Given this list of marker genes Egfr, Prss45, Cops5, Cma1, Ivns1abp, Prkn, Thop1, Capn12, Agbl4, Smurf1, Usp46, Hdac6, Kctd10, Psmb10, Fbxl7, Canx, Smurf2, Aopep, Mmp1a, Atxn3, Amz2, Ccdc47, Man1a, Yod1, Gzmf (granzyme F), Adamts17, Psen2, Klk1b4, Ankrd9, Dpep3, Nlrc4, Timp1, Usp42 (NCBI Gene Id 76800), Mbp, Psmd10, Ins1, Prss54, Lonp1, Pramel17, Tmprss11b, Ube3a, Cav1, Rnf150, Psme4, Wdr77, Rnf186, Pramel22, Serpinb10, Prss8, Cts6, Sgta, Kel, Armc8, Apc2, Arrb2, Arrdc4, Ero1b, Nedd4l, Try4, Shh, Clpx, Ubxn11, E330034G19Rik, Prss28 (serine protease 28), Gm15441, Ufd1, Tnp1, Adam6b, Chmp7, Ufl1, Cstdc4, Calr3, Klhl23, Usp37, Get4, Usp16, Tlk2, Psenen, Gclc, Rnf19a, Pidd1, Chmp2a, Cpa2, Rnf26rt, Klk7, Apoe, Ist1, F11, Tmprss7, Fbxo10, Brcc3, Htra2, Klhl4, Dnajb12, Snx9, Kbtbd6, Spink5, Ctsq (cathepsin Q), Adam15, Psme3ip1, Cfd, Ube4a, Ctsk, Senp1, Ptpn23, Lnpep, Usp1, Prkcq, Rnf144a, Trim32, Pramel25, Pramel53, Nupr1, Midn, Klk4, Rbp3, Saysd1, Trim38, Cpd, Kbtbd3, Faf2, Umod, Sh3rf1, Scrn1, Ube2l6, Trim9, Prpf19, Klhl20, Chmp2b, Fbxo48, Prickle1, Prss22, Immp1l, Senp5, Proc, Pramel31, Pcsk4, Osbpl7, Timm23, Ube2j2, Ptk2, Klhl6, Man1b1, Stambpl1, Adamts2, Sco1, Trim71, Pcsk7, Ovch2, Pramel32, Rbx1-ps (ring-box 1, pseudogene), Ecm1, Jmjd7 (jumonji domain containing 7), Psmd8, Ankrd11, Afg2b, Trim3, Gzmc, Cdc34, Clec16a, Rnf8, Tmprss9, Ide, Oga, Znrf4, Nemf, Cul1, Vps25, Mta1, Ddb1, Klk1b5, Dpp9, Actmap (NCBI Gene Id 434154), Pgpep1, Serpinb6c, Casp2, Axin1, Prss23, Serpinb6b, Bap1 (NCBI Gene Id 69465), Fbxo39, Bace2 (NCBI Gene Id 68803), Pja2, Dcaf13, Kctd6, Pitrm1, Anapc10, Tpsg1 (NCBI Gene Id 26945), Fbxo22, Foxf2, Maea, Spg7, Folh1, Dpp3, Dhh, Arxes1, Ttc3, Timp4 (NCBI Gene Id 21860), Cdk5rap3, Adam29, H2bc1, Sfrp2, Psme1, Corin, Pramel14 (NCBI Gene Id 670969), Cpne1, Adam24, Ace3, Ctsc, Ihh, Pramel6, Rnf10, Capn10, Cpa4, Adra2a, Rbmxl1, Mbtps1, Cul4a, Tdpoz3, Mindy1, Tmprss3, Efna3, Uba6, Ins2, Cdc27, Usp28, Cops3, Psma3, Pramel7 (NCBI Gene Id 97653), Map1a, Asprv1, Skp1, Cpxm1, Adam18, Ube2j1, Pga5, Usp38, Proz, Ipp, Tgfb1i1 (transforming growth factor beta 1 induced transcript 1), Dvl1, Ubr5, Anapc16, Cul3, Pramel38, Siah1a, Pramel33, Usp32, Pcsk2, Gapdhrt, Traf4, Serpinb9, Endou, Tmem259, Xbp1, Birc2, Adam1a, Adam3, Hipk2, Klhl17, Uspl1, Hspa5, Aph1b, Derl2, Cln5, Gm13040, Tpp1, Plaa, Mpnd, Cyfip2, Anxa2, Pramel47, Bmp1, Cnot4, Dtx3l, Mep1b, Anapc4, Klhl30, Ube2s, Snhg15, Prss36, Serpinb1b, Aph1a, Ubap1, Fau, Ctsl, Skp2, Ecscr, Tll2, Mindy3, Rnf170, Usp3, Psma2, Serpinf2, Tmem98, Rnf128, Dnajc3, Ubb, Prss39, Rnf126, Tdpoz5, Filip1l, Pramel13, Lats1, Hamp, Dcaf1, Otulin, Wdr26, Casp6, Cst7, Tspan15, Prmt6, Klhl7, Nhlrc1, Tinagl1, Cd46, Adam21, Matcap1, Bbs7, Parl, Usp18, Casp4, Cldn3, Brcc3dc, Serpinb9c, Psmb1, Otud7b, Hspbp1, Bfar, Topors, Agap3, Ctsh, Cstl1 (cystatin-like 1), Axin2, Pramel35, Nr1h2, Adam12, Mmp3, Psmb8, Ptpn1, Elane, Asb2, Zfand2a, Ctrc, Meltf, Ubxn2b, Det1, Anapc15-ps, Spcs1, Cpb2, Trim39, Bmal1 (NCBI Gene Id 11865), Ube2v2, Cpq, Sel1l, Tmem67, Fbxl2 (F-box and leucine-rich repeat protein 2), Klhl18, Rnf146, Tmub1, Pcbp2, Tysnd1, Spock1, Bag5, 1810009J06Rik, Fbxl15, Trp53inp2, Lap3 (leucine aminopeptidase 3), Pcsk6, Csnk1d, Klhdc3, Lactb, Herc2, Commd1 (COMM domain containing 1), Kctd17 (NCBI Gene Id 97993), Cpz, Kbtbd12, Yipf5, Nup98, Clca1, Rnf43, Prss40 (serine protease 40), Usp43 (ubiquitin specific peptidase 43), Map3k1, Ctsf, Styx, Mmel1, Spink2, Ptch1, Rnf216, Mkrn2, Pramel29, Atp13a2, Metap1 (NCBI Gene Id 99872), Oma1, Klhl12, Josd2, Acp4, Fbxl18 (NCBI Gene Id 231863), F12, Fbxo3, Adam20, Klk1b27, Adgrv1, Capn3, Gm2663, Rnf111 (ring finger 111), Cela3a, Ubxn10, Psmd13, Rgn, Plg, Sel1l2, Pramel12, Pramel24, Oog3, Rybp, Rack1, Agbl1, Snx33, Htra1, Cop1, Mib1, Glmn, Ubl7, Cndp1, Ogt, Asb9, Mindy4, Tmem208, Ift172, P4hb, Pik3c3, Cpa1, Immp2l, Ube2d2a, Lrrc75a, Fbxo11, Pisd, Afg1l, Ctsa, Ubqln2 (ubiquilin 2), Psma6, Pramel43, Tmem168, Klhl15, Rhbdl3, Prss44, Rhbdl2, Hint1, Ltn1, Adam19, Akt1, Ermp1, Rpl5, Clgn, Desi2, Epm2a, Enpep, Vps37b, Chfr, Klk1b1 (NCBI Gene Id 16623), Rnf180, Sirt1, Usp45, Rnf121, Usp7, Ccdc22 (NCBI Gene Id 54638), Vhl (NCBI Gene Id 22346), Fbxo8, Cdc34b, Fbxl19, Fhit, Tdpoz1, Psma8, Prss3, Pkd1, Serpinb9f, Rnf103, Tspan5, Pramel30, Traf3, Zyg11b, Gzmg, Pramel19, Csnk1e, Edem2, Lrig2, Pten, Afg3l2, Gzmb, Spink1, Pramel28, Rcn3, Amz1, Lrrk2, Usp36, Gabarap, Cdc26, Ece1, Cela3b, Brsk2, Ctsd, Ube2z, Psmb3, Znrf2, Vps4a, Ube2g2, Cpn1, Usp17le, Cyld, Anapc1, Espl1, Pramel15, Prss58, Usp33, Pramel23, Adam10, Pramel18, Trim26, Habp2, Eno1b, Capn8 (calpain 8), Adamts20, Ube3b, Oaz1, Rffl, Rnf123 (NCBI Gene Id 84585), Dcaf11, Gzmn, Fbxl17, Rhbdf1 (NCBI Gene Id 13650), Hspa1a, Rnf115, Ubxn4, Gzmd, Csta2, Rmnd5b, Plk3, Lvrn, Mmp12, Gzme, Eef1ece2, Pcsk1, Timp2, Fadd, Chmp1a, Mindy2, Siah2, Gapdhrt2, Nop53, Nccrp1, Psma7, Pappa2, Spopfm2, Astl, Serpinb9b (serine (or cysteine) peptidase inhibitor, clade B, member 9b), Prss2, Dpp6, Pcyox1l, Apc, Rbx1, Cdc20, Metap2, Csnk1a1, Derl3, Pcyox1, Napsa, Usp4, Slc30a8, Ubac2, Npepl1, Capn15, Rnf185, Cul9, Cast, Hspa8, Psmd3, Spock3, Adamts19, Sppl2a, Comp, Vps28, Chmp4c, Otud6b, Usp34, Ift52, C1rb, Serpinb9h, Sumo1, Tpsab1, Tnf, Zmpste24, Ctnnb1, Myc, Dync2h1, Kbtbd2, Kat5, Usp17lc, App, Alg13, Usp24, Vash2, Ctsj, Perp, Sva, Ecel1, Adamts8 (NCBI Gene Id 30806), Socs2, Gsk3b, Serpinb6d, Dlgap1, Rnf144b, Mmp25 (matrix metallopeptidase 25), Fbxl12, Trib2, Psmb11, Pepd, Prss38, Vash1, Clpp, Egf, Cdh1, Adam26a, Rnf26, Capn11, Herpud1, Fbxw8, Appbp2, Otub1, Adam8, Rnf149, Tpp2, Hace1, Fbxl6 (F-box and leucine-rich repeat protein 6), Trim31 (NCBI Gene Id 224762), Pbk, Herc4, Desi1, Ube2u, Tbl1xr1, Klk14, Serpinb13, Mmp9, Fbxl20, Nedd8, Matcap2, Capn7, Ren1, Adamts5, Chmp1b2, Vps37d, Hp, Adam34l, Syvn1, Dpep2, Klhl5, Disp1, Mbl2, Casp8, Ubqln3, Klhl24, Fbxo9, Stoml2, Edem3, Socs4, Cntn2, Ntan1, Chst8, Tmem129 (transmembrane protein 129), Prss3b, Nrros, Pmpcb, Zfp598, Huwe1, Hspa1b, Socs7, Pdcl3, Rab23, Hecw1, Adamts6, Usp21, Ube2d3, Kdm8, Prss53, Fetub, Tasp1, Senp2, Fuz, Prss37, Oog1, Cfh, Gan, Cela2a, Prelid1, Inpp5b, F9, Gba1, Ecpas, Serpinb8, Acr, Pdcd6ip, Prss57, Arel1, Blmh, Mst1, Cul5, Serpinb1c, Adamts9, Lmln, Prss3l (NCBI Gene Id 100044144), Dpp4, Senp6, Ager, Serpinb9d, Atp6ap2, Il1b, Trim25, Prcp, Phf20l1, Cfhr4, Dpep1, Kbtbd7, Rnf7, Klk1b22, Cpa5, Dtx4, Ctrb1, Rnf25, Pramel48, Gzma, Vcp, Tmub2, Ky, Csta3, Stambp, Tmprss11e, Dnpep, Uchl5, Rnf5, Fbxo44 (NCBI Gene Id 50763), Rnf133, Rfx4, Fbxl22, Psmf1, Vps4b (vacuolar protein sorting 4B), Rnf148, Sec11c, Dab2ip, Cln3, Cfi, Nfe2l2, Nln, Pgc, Rnf13, Otub2, Prss1, Ift80, Ctsr, Stfa2, Fkrp, Hgf, Gabarapl2, Usp48, Ube2l3 (NCBI Gene Id 98018), Scg5, Ltf, Hid1, Rhobtb3 (NCBI Gene Id 74794), Oxa1l, Mipep (mitochondrial intermediate peptidase), Anapc5, Adam11, Ufsp2, Klk1b3, Adam23, Cdc20b, Nrdc, Mtm1, Ecrg4, Uqcrc2, Psmc3, Cpxm2, Atg4a, Socs6, Klhdc10, Rad23a, Cts7, Ddi1, Ctss, Tnfaip1, Wnt1 (NCBI Gene Id 22408), Klhl22, Rnf20, Ift88 (NCBI Gene Id 21821), Prtn3 (proteinase 3), Ctsw, Adam33, Prss34 (serine protease 34), Cstdc3, Rgma, Cym, Znrf3, Vps37a, Atg4b, Mbtps2, Mmp7, Eif3h, Isg15, Oog4, Fbxl4, Prss29, Prss33, Casp12, Klhl10, Casp9, Sppl3 (NCBI Gene Id 83678), Pcolce, Cirop, Rspry1, Fga, Colec11, Ube2c, Trib3, Dtl, Rhbdd1, Pm20d1 (peptidase M20 domain containing 1), Ccar2, L3mbtl3, Tpsb2 (tryptase beta 2), Mysm1, Rhbdf2, Adamts3, Kcmf1, Otud5, Spsb1, Tmprss11d, Pml, Tdpoz9, Pcsk9, Ret, Herc3, Xpnpep2, Trpc4ap, Metap1d, Pramel5, Ube3c, Wwp1, Psme2, Mcpt9, Lonrf2, Chac1, Ubl4a, Angptl8, Rc3h2, Dcaf12, Usp19, Wfdc6a, Eloc, Ddrgk1, Klk1b24, Serpine2, Cndp2, Atg4c, Ubxn8, Prkaca, Tmprss13, Cbfa2t3, Atg7, Epg5, Ubqlnl, Ubqln4, Tmprss5, Klhl42, Phex, Hectd1, Cul7, Snf8, Ifng, Adamts14, Gna12, Ercc8, Ctsz, Arxes2, Chmp4b, Adam5, Pramel45, Arih2, Kctd5, Klk8, Pramel16, Tmprss4, Cul4b, Ggt5, Rnf139, Cplane2, Prkacb, Usp50, Mafb, Rnft1, Rchy1, Alad, Tm4sf20, Prss16, Spopfm3, Cpe, F3, Tgfb1, Tnp2, Ptpn3, Arrdc1, Adamts1, Afg3l1, Klhl41, Trem2, Serpinb1a, Klk1b16, Casp1, Pgpep1l, Ctnnd1, Rnf40, Il1r2, Gpx1, Capn9, Hgfac, Vps37c, Sufu, Cstdc6, Usp22, Anapc15, Klhl8, Trim67, Klhdc2, Pip, Sirt4 (NCBI Gene Id 75387), Rnf130, Sec61b, Tmf1, Asb11, Arrb1, Hjv, Rps7, Clu, Bace1, Dag1, Socs5, Adam25, Mmp11, Herc6, C1ra, Gzmk, Ubqln5, Sharpin, Vps35, Sh3rf3, Pabpn1l, Adamts7, Psmd11, Myrf, Spink6, Wac, Sval1, Pramel21, Fmr1 (fragile X messenger ribonucleoprotein 1), Usp44, Erlin2, Ccnf, Fbxo27, Cpa6, Prss21, Psma4, Dpp10, Dnajb2, Trim13, Pramel51 (NCBI Gene Id 100039315), Tspan17, Cstdc5, Klhl21, Adam4, Spink12, Fap, Cuzd1, Psme3, Cldn4, Rnf7l, Rnf166, Otud3, Ctsg, Crbn, Pm20d2, Prss56, Tbx21, C1s2, Pcsk1n, Uba52, F10, Ube2g1, Ern1, Pramel26, Rbck1, Ube2h, Usp5, Ctse, Zer1, Uchl1, Siah1b, Adamts15, Ubqln1 (NCBI Gene Id 97856), Pramel60, Mme, Vsir, Aph1c, Nrip2, Serpine1 (NCBI Gene Id 231790), Adam28, Ube2k (NCBI Gene Id 53323), Notch4, Klhl38, Serpinb6a, Htra4, Mmp13, Lta4h, Otud4, Fbxo38, Svip, Atg4d, Fbxl14, Ube2b, Mmp15, Lgmn, Uchl4, Ube2d1, Rnf168, Psmb7, Prss43, Nlrp1b, Wfikkn1, Scpep1, F8a, Ece2, Mcpt1, Gapdh, Uba7, Fgfr4, Reck, Klhl1, Fbxo17, Prss41, Ufsp1, Yme1l1, Asph, F2, Pappa, Adam39, Trabd2b, Wfs1, Tmprss12, Lnx1, Cacul1, Scrn3, Anapc11, Kif14, Ace, Sppl2c, Tmprss15, Styx-ps, Cdkn2a, Otud7a, Plk2, Casp14, Pmp22, Ube2srt, Psmd4, Casp7, Ttc36, Cntnap5a, Nudt15, Trib1, Traf7, Spsb4, Adam1b, Ubxn7, Psma1 (proteasome subunit alpha 1), Gipc1, Furin (furin, paired basic amino acid cleaving enzyme), Ankzf1, Ubc, Psmb2, Mmp21, Plgrkt, Hectd3, Klhl2, Pigk, Usp14, Fbxl9, Stat3, Srgn, Atp23, Pmaip1, Ubxn1, Fcnb, St14, Ube2w, Parp1, Mapk8, Apoh, Chmp1b, Itch, Usp27x, Adam34, Pramel44, Mmp17, Rpl23, Rhbdl1, Pik3r1, Klhl40, Ace2, Ctsm, Usp10, Prep, Tmed10, Anapc7, Rnf11, Hsp90ab1, Fbxo45, Capns1, C2cd3, Laptm5, Nrip3, Psmb9, Wwtr1, Tmtc3, Spopl, Kcne2, Usp25, Mcpt8, Adamts18, Bak1, Psmc5, Irgq, Ubxn2a, Fem1c (NCBI Gene Id 67174), Glg1, Usp29, Usp26, Spon1, Tbc1d10a, Serpina5, Ophn1 (NCBI Gene Id 94190), Prss42, Rnpep, Eno1, Taf9, Psmd7, Clec3b (NCBI Gene Id 21922), Usp47, Ascc3, Fem1b, Dab2, Myrfl (NCBI Gene Id 237558), Ctla2a, Adamts10, Ctrl, Selenos, Adamdec1, Src, Capn6, Pithd1, Ark2n, Tor1a, Usp17la, Cldn13, Clca3a1, Usp13, Anapc2, Naaladl1, Dpp7, Fbxl5, Ubr2, Asrgl1, Chmp3, S100a10, Klhl29, Mep1a, Xpnpep1, Lyn, Jkamp, Epha4, Klk1b9, Ppp1r11, Ube2dnl1, Rpgr, Slc30a5, Eif2a, Uba1, Otud6a, Wdr81, Os9, Uchl3, Ubd, Ccbe1, Spcs2, Adamts12, Mmp8, Hdac2, Psmd2, Masp1 (NCBI Gene Id 17174), Gid4, Reln, Rpl11, Klkb1, Pramel40, Ubr1, Gapdh-ps15, Siah3, Akirin2 (akirin 2), Rnf41, Calr4, Tmprss11c, Aebp1, Cd2ap, Senp3, Nub1 (NCBI Gene Id 80634), C1rl, Man1c1, Dda1, Cpb1, Sirt2, Timp3, Rce1, Gsn, Psen1, Rnf114, Prss1l, Dnaaf4, Gid8, Tmx1, Sh3rf2, Aqp11, Ate1, Capn13, Ncstn, Pthlh, Man1a2, Spsb2, Senp8, Trp53, Tmprss6, Cfb, Usp12, Dmac2, Hecw2, Mmp14, Rbbp6 (NCBI Gene Id 97359), Snx12, Gsk3a, Psmd1, Thbs1, Tsg101 (NCBI Gene Id 22088), Ambra1, Csnk2b, Rps6ka2, Psmb6, Ube2r2, Nsfl1c, Il33 (interleukin 33), Anpep, Sirt6, Sumo3, Zswim8, Pramel1, Agtpbp1, Ube3d, Sprtn, Cts8, Agbl3, Zfp418, Tmprss2, Cdc23, Dcst1, Fbxo6, Tdpoz4, Hpn, Vps36, Prss32, Adam6a, Stfa1, Trim28, Bcap31, Edem1, Adam30, Pramel11, Cpm, Bin1, Rnf34, Ptk2b, Pramel27 (PRAME like 27), Fbxo4 (NCBI Gene Id 67521), Adam7, Tdpoz2, Rad23b, Prss50, Hsp90b1 (heat shock protein 90, beta (Grp94), member 1), Brinp1 (bone morphogenic protein/retinoic acid inducible neural specific 1), Capn5, Cts3, Rnf4, Agbl5, Casp3, Cflar, Timm17a, Crb2, Cbl, Serpinb9g, Fbxl13, Ubr4, Tmprss11f, Pacsin3, Cstb, Calr, Derl1 (NCBI Gene Id 67819), Csnk2a2, Nlrp1a, Pabir1, Fbxw4, Psmc1, Eif2ak3, Pramel20, F7, Ctsll3, Anapc13 (anaphase promoting complex subunit 13), Hfe, Nfe2l1, Chmp6 (NCBI Gene Id 69715), Rnpepl1, Nr1h3, Psmd14, Lamp3, Svbp, Usp17ld, Klk1b8, Caml, Stub1, Try10, Fbxw5, Rnf19b, Nkd2, Klhdc1, Usp54, Vtn, Xpnpep3, Masp2 (MBL associated serine protease 2), Asb1, Plaur, Klhl35, Ube2d2b, Sval3, Klhl3, Psmc6 (proteasome (prosome, macropain) 26S subunit, ATPase, 6), Aurkaip1, Tmprss11g, Cblc (Casitas B-lineage lymphoma c), Eif3f, Prss46, Gsap, Csta1, Rnf145 (ring finger protein 145), Fgg, Adamts16, Rnf215, Rps27a, Ppp1r15a, Fbxl3, Mmp16 (matrix metallopeptidase 16), Stam, Znrf1, Grn, Mmp24, Amfr, Ndfip1, Adam22 (a disintegrin and metallopeptidase domain 22), Trim45 (tripartite motif-containing 45), Fam111a, Capn1, Adam9, Klk1b21, Usp30, Ccin, Ube2a, Kctd13, Clca4a, Keap1, Cela1, Klk1b11, Pcnp, Fbxo7, Faf1, Naglu, Rc3h1, Psmb4, Cfl1, Usp9x, Adamts13, Usp9y, Ctso, Bad, Kng2, Tnfrsf1b, Ctsb, Npepps, Marchf7, Dhcr24, Kng1, Zranb1, Hmces, Proca1, Pramel41, Fem1al, Apeh, Antxr1, Dpp8, Mmp10, Sec11a, Kbtbd8, Nedd4, Kctd2, P2rx7, Psmb5, Lonp2, Sh3bgrl, Pramel46, Peli1, Mmp19, Mdm2, Qrich2, Gli3, Trhde, Capn2, Usp2, Klk13, Rbmx, Fem1a, Psma5, Marchf6, Btrc, Prkcg (protein kinase C, gamma), Fbxl16, Plk1, Klk12, Prss30, Ppp2r5c, Ascc2, Usp40, Rnf187, Smarcc1, Pcsk5, Mtor (mechanistic target of rapamycin kinase), Sppl2b, Foxred2, Sec61bl, Trim63, Tnfaip3 (NCBI Gene Id 21929), Fgb, Cpvl, Ndfip2, Fbxo31, Disc1, Usp11, Psmc4, Gpld1, Myh9, Cdk5, Dld, Htra3, Trim72, Bag2, Zfand2b, Fbxw7, Uhrf1, BC051665, Klk1, Prss55, Klhl28, Anks1, N4bp1, Prss48, Rnf213, Chmp5, Tgm2, Pias1, Mcpt2, Ldlrad3, Plat, Erlin1, Fbxw11, Gm4787, Ggt1, Trip12, Spcs3, Sh3d19, Otud1, Clock, Senp7, Fzr1, Dnajc10, Stfa2l1, Klhl25, Mmp23, Adam2, Wnt10b, Tbl1x, Malt1, C2, Sdf2l1, Pmpca, Pramex1, Pramel42, Ankib1, Trf, Pramel37, Araf, Adam26b, Cln6, Psmd6, Cpa3, Fxn, Vcpip1, Spop, Rnf14, Enc1 (ectodermal-neural cortex 1), Uba1y, Eppin, Ubr3, Clca2, Kctd21, Ube2n, Usp8, Ppp2cb, Ddit3, Spsb3, Tmem126a, Try5 (NCBI Gene Id 445265), Mmp2, Klk11, Pramel55, Nhlrc3, Tdpoz8, Aga, Plau, 4930486L24Rik, Arih1, Colec10, Tmprss11a, Fbxo2, Usp20, Rmnd5a, Tollip, Usp51, Rnf167, Ube2dnl2, Rybp-ps, Ddi2, Rnf125, Nr1d1, Trim21, Sde2, Erlec1, Atp5if1, Xpo1, Cdc16, Stt3b, Aurka, Aup1, Naalad2, Liat1, Oog2, Prepl, Ep300 (NCBI Gene Id 328572), Trip4 (NCBI Gene Id 75366), Prss52, Klhl11, Prss12, Park7, Rlim, Rnf122 (ring finger protein 122), Mcpt4, Atg4a-ps, Scrn2, Trim58, Rnf6, Trim2, Bag6, Adgb, Cst3, C1s1, Usp17lb, Wwp2, Efna1, Pramel36, Agbl2, Adam32, Dnajb9, Paqr3 (NCBI Gene Id 70746), Sval2, Cwh43, Mmp1b, Mylip, Tank, Amn1, Adam17, Il10, Stfa3, Adamts4, Klk1b26, H13 (NCBI Gene Id 99254), Ubxn6, Serpinb6e, Josd1, Rnft2, Pgk1, Usp15, Erap1, Cul2, Prss27, Sumo2, Serpinb7, Usp49 (NCBI Gene Id 224836), Nploc4, Serpinb9e, Ubap1l, Mmp20, Psmc2, Gas1, Ube4b, Rnf217, Mapk9, Tll1, here is a description of the gene set: Mouse Gene Set: GOBP_PROTEOLYSIS studied in species Mus musculus The hydrolysis of proteins into smaller polypeptides and/or amino acids by cleavage of their peptide bonds.